The following is a description of a gene set: species: Mus musculus Mouse Gene Set: GOBP_REGULATION_OF_BONE_REMODELING Any process that modulates the frequency, rate or extent of bone remodeling, the processes of bone formation and resorption that combine to maintain skeletal integrity., and this is the list of marker genes: Fcgr4, Il20ra, Cldn18, Lep, Ubash3b, Plekhm1, Ptger4, Car2, Dcstamp, Nf1, Trf, Suco, Itgav, Cartpt (NCBI Gene Id 27220), Iapp, Fshb, Inpp5d, Ppargc1b, Tmem119, Syt7, S1pr1, Gpr137, Dlk1, Csf1r, Inpp4b, Tmem64, Fshr, Gpr137b, Pdk4, Tfrc, Cd38 (NCBI Gene Id 12494), Calcr, Spp1, Il6, Mc4r, Arap1, Adam8, P2rx7, Syk, Sfrp1, Ceacam1, Oscar, Tnfsf11, Cyp19a1, Fgfr3, Grem1, Slc4a2, Siglec15, Tnfrsf11a, Gja1, Src, Csk, Idua, Vegfa, Def8, Prkca, Rufy4, Ltbp3, Tnfrsf11b, Hamp, Lrp6, Egfr, Ahsg, Mdk, Itgb3, Lepr